Given this list of marker genes HAS1, MAP3K8, FGF9, PDZRN4 (NCBI Gene Id 29951), SFTPD, NSA2P7, RN7SL101P, GADL1, MEGF6, KRTDAP, EPCIP, HDAC1P1, RPRD1B, ADAMTSL4-AS1, PLCB1, PSAPL1, KLK10, PODN, EGOT, MIR548XHG, TSHZ3-AS1, GFPT2, LINC02364, RND1, LAMC2, RNU4-45P, ALOX15, FENDRR, NFATC2, GLP2R, SFTPD-AS1 (SFTPD antisense RNA 1), CA11, RPL31P52, BDKRB1, here is a description of the gene set: from publication Cao J, O'Day DR, Pliner HA, Kingsley PD, Deng M, Daza RM, Zager MA, Aldinger KA, Blecher-Gonen R, Zhang F, Spielmann M, Palis J, Doherty D, Steemers FJ, Glass IA, Trapnell C, Shendure J (PMID 33184181) The gene expression program underlying the specification of human cell types is of fundamental interest. The study authors generated human cell atlases of gene expression and chromatin accessibility in fetal tissues. For gene expression, the study authors applied three-level combinatorial indexing to >110 samples representing 15 organs, ultimately profiling ~4 million single cells. The study authors leveraged the literature and other atlases to identify and annotate hundreds of cell types and subtypes, both within and across tissues. Our analyses focused on organ-specific specializations of broadly distributed cell types (such as blood, endothelial, and epithelial), sites of fetal erythropoiesis (which notably included the adrenal gland), and integration with mouse developmental atlases (such as conserved specification of blood cells). These data represent a rich resource for the exploration of in vivo human gene expression in diverse tissues and cell types. species: Homo sapiens Human Gene Set: DESCARTES_MAIN_FETAL_MESOTHELIAL_CELLS Marker genes curated from the annotated cluster as represented in the Descartes Human Gene Expression During Development database.